The following is a description of a gene set: species: Homo sapiens Unicoronal synostosis Synostosis affecting only one of the coronal sutures. Human Gene Set: HP_UNICORONAL_SYNOSTOSIS, and this is the list of marker genes: TCF12, CEP120, TWIST1, ZEB2, PIGO, SMO (smoothened, frizzled class receptor), MSX2